Given this list of marker genes TGFBR3 (transforming growth factor beta receptor 3), BSCL2, ABCA13, CCND2, CD177, RNF128, GDA, TNFSF13, ALAS1, CTNND1, HSD11B1, THBS1, IGSF6, TLR4, KMT2A, CLEC7A, ELANE, RHOJ, MTUS1, CCNB1, B4GALT6, CSF2RA, PRTN3, TFEC, MPO, SORT1, BMI1, PDE2A, MS4A3, SLFN12, MYB, here is a description of the gene set: species: Mus musculus Human Gene Set: WANG_IMMORTALIZED_BY_HOXA9_AND_MEIS1_UP from publication Wang GG, Pasillas MP, Kamps MP (PMID 15755900) Up-regulated genes in myeloid progenitors immortalized by HOXA9 vs those immortalized by HOXA9 and MEIS1. Meis1 is a homeodomain transcription factor coexpressed with Hoxa9 in most human acute myeloid leukemias (AMLs). In mouse models of leukemia produced by Hoxa9, Meis1 accelerates leukemogenesis. Because Hoxa9 immortalizes myeloid progenitors in the absence of Meis1 expression, the contribution of Meis1 toward leukemia remains unclear. Here, we describe a cultured progenitor model in which Meis1 programs leukemogenicity. Progenitors immortalized by Hoxa9 in culture are myeloid-lineage restricted and only infrequently caused leukemia after more than 250 days. Coexpressed Meis1 programmed rapid AML-initiating character, maintained multipotent progenitor potential, and induced expression of genes associated with short-term hematopoietic stem cells (HSCs), such as FLT3 and CD34, whose expression also characterizes the leukemia-initiating stem cells of human AML. Meis1 leukemogenesis functions required binding to Pbx, binding to DNA, and a conserved function of its C-terminal tail. We hypothesize that Meis1 is required for the homing and survival of leukemic progenitors within their hematopoietic niches, functions mediated by HSC-specific genes such as CD34 and Fms-like tyrosine kinase 3 (FLT3), respectively. This is the first example of a transcription factor oncoprotein (Meis1) that establishes expression of a tyrosine kinase oncoprotein (FLT3), and explains their coexpression in human leukemia. This cultured progenitor model will be useful to define the genetic basis of leukemogenesis involving Hoxa9 and Meis1.